The following is a description of a gene set: Ribs with a reduced diameter. species: Homo sapiens Thin ribs Human Gene Set: HP_THIN_RIBS, and this is the list of marker genes: PPP3CA, ZMPSTE24, COL1A2, MAMLD1, KLHL41, COL1A1, LMOD3, COL11A1, MUSK, MTMR14, SERPINH1, WNT1, KLHL40, SKI, CUL7, LMNA, LAMA5, CCDC8, MTX2, TOMM7, SEC24D, RTTN, BANF1 (barrier to autointegration nuclear assembly factor 1), TRPV6, CHRNG, DNM2, P3H1, CHRNA1, TBCE, FAM111A, MYF6, PDGFRB, PLOD1, ACTA1, HDAC6, COL2A1, SCN4A, POLR3A, LIFR (NCBI Gene Id 3977), EXOC6B, RYR1, NEB, SCARF2, SOX9, CHRND (NCBI Gene Id 1144), AIFM1, BIN1, OBSL1 (obscurin like cytoskeletal adaptor 1), TENT5A, MTM1, USP18, ORC1